The following is a description of a gene set: Using a cDNA microarray analysis, we identified x-ray-inducible immediate early response factor-1 (IEX-1) as a proapoptotic gene which was induced by TNF-alpha and also depend on NF-kappaB activation in Hc human hepatocytes. In these cells only the original form of IEX-1, termed IEX-1S, but not its longer transcript IEX-1L, was expressed. Overexpression of IEX-1S resulted in promotion of TNF-alpha-induced apoptosis in Hc cells expressing a mutant form of IkappaB. This proapoptotic action can be explained by its inhibitory findings on survival signals; inhibition of TNF-alpha-induced activation and expression of phosphatidylinositol 3-kinase (PI3K)/Akt, and also blockage of expression of Mcl-1, an antiapoptotic Bcl-2 family member which is located downstream of Akt, was inhibited by IEX-1S. LY 294002, an inhibitor of PI3K, increased IEX-1S expression induced by TNF-alpha and accelerated TNF-alpha-induced apoptosis in IkappaB-treated Hc cells. Overexpression of the dominant-negative Akt enhanced, but the constitutively active Akt suppressed, TNF-alpha-induced IEX-1S expression, suggesting that PI3K/Akt negatively regulated IEX-1S expression. These results demonstrate that NF-kappaB-dependent recruitment of IEX-1S may play a proapoptotic role in TNF-alpha-stimulated hepatocytes through blockage of the PI3K/Akt pathway. Moreover, the reciprocal cross-talk between IEX-1S and PI3K/Akt may closely be involved in the regulation of TNF-alpha-induced hepatocyte apoptosis. from publication Osawa Y, Nagaki M, Banno Y, Brenner DA, Nozawa Y, Moriwaki H, Nakashima S (PMID 12682234) Human Gene Set: OSAWA_TNF_TARGETS species: Homo sapiens Genes up-regulated in Hc cells (normal hepatocyte) by TNF., and this is the list of marker genes: TP53BP2, CXCL8, CFLAR, COL3A1, JAG2, LPAR2, HABP2, TNFAIP2, IER3, EFNA1